The following is a description of a gene set: studied in species Homo sapiens part of: Drug resistance of FLT3 mutants Reactome Pathway: KW2449-resistant FLT3 mutants KW-2449 is a second generation, type I aurora kinase and FLT3 tyrosine kinase inhibitor, Despite effectiveness against a number of FLT3 mutant alleles, it has been withdrawn from development due to poor pharmacodynamics. This pathway describes FLT3 mutants that are resistant to inhibition by KW-2449., and this is the list of marker genes: FLT3